Given this list of marker genes STAT6, GTF3C1, RGS19, TUBA3C, CRADD, NUP214, ENTPD1, TAOK3, SPTLC1, ADGRE5, GSK3B, MYCBP, PIGB, GNAT2, TKT, MAP2K4, GALNT3, MAPK3, MBD4, RBMS1P1, RARA, MAP3K3 (NCBI Gene Id 4215), CBX1, MARK2, LSP1, ZNF185 (NCBI Gene Id 7739), TLR1, PPP1R12A, DHX9 (NCBI Gene Id 3450), SPAST, TWF2, TBPL1, ZMPSTE24, NCOA4, TCAP, ATP6V0E2, TSC22D3, ICAM3, LILRA2, BARX2, SLC19A1, RERE, GTF2I, RASGRP2, CD46, CAMK2G, LST1, RIPK1, UBA3, GNAQ, TLR6, TUBA4A, PEX1, PRMT2, SLC25A3 (solute carrier family 25 member 3), HSBP1, CDK13, COPS5, LASP1, USP1, RABIF, ST8SIA4, RPS6KA5, SEC14L1, XPC, STK38, NCOA1, FOXO4, ANXA11, MTMR3, GCA, SMARCA2, GNAI2, OGT, CELF2, CXCR1, RGS14, UBN1, ARID4A, ARHGAP1, ACLY, SRSF4, PPP1CA, DAPK2, SRSF1, POLR2J (RNA polymerase II subunit J), NPEPPS, CYTH1, RASA1, RALY, FLII, APAF1, PPM1A, ARHGAP4, TST, CREBBP, DOCK2, CPNE3, PPP1CC, GNAO1, AKT1, CASP8, VIM, ARHGDIB, PRCP, TRIM27, FLOT2, IQGAP1 (IQ motif containing GTPase activating protein 1), INPP5D, LRRFIP1, HNRNPUL1, HSF1, MYO9B, ME2, ACTN4, ROCK1, ADAM10, GRK2, SET, TGFA, DDX23, CXCR2, PHKA2, ITPKB, CAPZB, TAF4, HTATIP2, TADA3, PHKB, PDE3B, ARPC1B, PRDX3, CITED2, SLC23A2, TIAL1, TOPBP1, TYK2, FOXO1, IDS, GNAS, LBR, SMC1A, RPS6KA1, GDI2, LILRB5, RBL2, MEIS2, TOB1, PPFIA1, GNB2, SRPK2, ZFP36L2, XRCC5, HMGB2, ZNF217, HDAC5, ITGB2, CBFA2T3, RGS2, FLI1, FKBP1A, CSF3R, COX5B, ADD3, PLCB2 (phospholipase C beta 2), RBM5, TPST2, OAZ1, ARPC3, ARHGEF1, GTF2B, WAS, FEZ2, TUBA1B (NCBI Gene Id 88851), ATRX, STK24, NCF4, MAPKAPK3, NFE2, HHEX, ACTN1, PLCG2, JAK1, RO60, SLC31A2, SELPLG, PRKAR1A, ULK1, CSTA (cystatin A), S1PR4, RALBP1, CORO1A, SNAP23, CCZ1, GAS7, CDIPT, TNPO3, PRKCB, GTF2E1 (NCBI Gene Id 2960), TBCC, UQCR11, RAF1, LTB, MAP3K5, FADD, RCBTB2, STX16, GPR19, ACVR1B, KLC1, SRP9, YY1, CALM2, TGFB1, UPF1, CALM1, EIF4G2, PITPNM1, PNN, ABCG1, NUP153, IGF2R, PPP1R12B, PHC2, CDKN2D, USP15, HCLS1, here is a description of the gene set: from publication Theilgaard-Mönch K, Knudsen S, Follin P, Borregaard N (PMID 15187151) species: Homo sapiens Human Gene Set: THEILGAARD_NEUTROPHIL_AT_SKIN_WOUND_DN To investigate the cellular fate and function of polymorphonuclear neutrophilic granulocytes (PMNs) attracted to skin wounds, we used a human skin-wounding model and microarray technology to define differentially expressed genes in PMNs from peripheral blood, and PMNs that had transmigrated to skin lesions. After migration to skin lesions, PMNs demonstrated a significant transcriptional response including genes from several different functional categories. The up-regulation of anti-apoptotic genes concomitant with the down-regulation of proapoptotic genes suggested a transient anti-apoptotic priming of PMNs. Among the up-regulated genes were cytokines and chemokines critical for chemotaxis of macrophages, T cells, and PMNs, and for the modulation of their inflammatory responses. PMNs in skin lesions down-regulated receptors mediating chemotaxis and anti-microbial activity, but up-regulated other receptors involved in inflammatory responses. These findings indicate a change of responsiveness to chemotactic and immunoregulatory mediators once PMNs have migrated to skin lesions and have been activated. Other effects of the up-regulated cytokines/chemokines/enzymes were critical for wound healing. These included the breakdown of fibrin clots and degradation of extracellular matrix, the promotion of angiogenesis, the migration and proliferation of keratinocytes and fibroblasts, the adhesion of keratinocytes to the dermal layer, and finally, the induction of anti-microbial gene expression in keratinocytes. Notably, the up-regulation of genes, which activate lysosomal proteases, indicate a priming of skin lesion-PMNs for degradation of phagocytosed material. These findings demonstrate that migration of PMNs to skin lesions induces a transcriptional activation program, which regulates cellular fate and function, and promotes wound healing. Genes down-regulated in polymorphonuclear neutrophilic granulocytes (PMNs) attracted to skin wounds.